The following is a description of a gene set: Five modified nucleotides have been detected in the 12S rRNA: 5-methylcytidine-841 catalyzed by NSUN4, 6-dimethyladenosine-936 catalyzed by TFB1M, 6-dimethyladenosine-937 catalyzed by TFB1M, 5-methyluridine-429, and 4-methylcytidine-839. Four modified nucleotides have been detected in 16S rRNA: 2'-O-methylguanosine-1145 catalyzed by MRM1, 2'-O-methylguanosine-1370 catalyzed by RNMTL1 (MRM3), 2'-O-methyluridine-1369 catalyzed by FTSJ2 (MRM2), and pseudouridine-1397. 2'-O-methyluridine-1369 and 2'-O-methylguanosone-1370 occur in the A-loop of rRNA which is located at the peptidyl transferase center of the large subunit. Here the modified residues play a role in interaction with the aminoacyl site of tRNA. Knockouts of TFB1M and NSUN4 are lethal in mice and mutations in TFB1M may be related to aminoglycoside-induced deafness. part of: rRNA processing in the mitochondrion Reactome Pathway: rRNA modification in the mitochondrion species: Homo sapiens, and this is the list of marker genes: MRM3, MTERF4, MT-RNR2, MRM1, MT-RNR1, RPUSD3, MTERF3, FASTKD2 (FAST kinase domains 2), RPUSD4, NGRN, TFB1M, TRUB2, MRM2, RCC1L, NSUN4